Given this list of marker genes KIR3DL2, MNDA, CXCL9, LBP, NCR1, RAB23, FOSL1, KLRC2, CLEC5A, IL33, KLRC3, UMOD, CX3CR1, HLA-G, ITK (NCBI Gene Id 3702), CCR2, LGALS3BP, DCDC2, NCF1, KIR2DL4, CCR3, RELA, FCMR, ZNF148, CD5L, CD300C, LY96, CCR9, TYROBP, C5AR1, CXCR2, PTK2B, IL1RL2 (interleukin 1 receptor like 2), TRAT1, TCIRG1 (NCBI Gene Id 8845), NCR2, BCL10, GNLY, BECN1 (beclin 1), KIR2DS3, LSP1, SH2D1A, ITGB1, CCR5, VEZF1, ADORA2A, SPN, NCF2, PRF1, KLRG1, CCR6, LILRB2, here is a description of the gene set: species: Homo sapiens Human Gene Set: GOBP_CELLULAR_DEFENSE_RESPONSE A defense response that is mediated by cells.